The following is a description of a gene set: Any process that activates or increases the frequency, rate or extent of the chemical reactions and pathways involving amines. species: Homo sapiens Human Gene Set: GOBP_POSITIVE_REGULATION_OF_AMINE_METABOLIC_PROCESS, and this is the list of marker genes: VPS35, GPR37, PARK7, NPY, HPRT1, PAOX, ABAT